The following is a description of a gene set: from publication Mili S, Moissoglu K, Macara IG (PMID 18451862) studied in species Mus musculus Mouse Gene Set: MILI_PSEUDOPODIA_HAPTOTAXIS_DN RNA localization is important for the establishment and maintenance of polarity in multiple cell types. Localized RNAs are usually transported along microtubules or actin filaments and become anchored at their destination to some underlying subcellular structure. Retention commonly involves actin or actin-associated proteins, although cytokeratin filaments and dynein anchor certain RNAs. RNA localization is important for diverse processes ranging from cell fate determination to synaptic plasticity; however, so far there have been few comprehensive studies of localized RNAs in mammalian cells. Here we have addressed this issue, focusing on migrating fibroblasts that polarize to form a leading edge and a tail in a process that involves asymmetric distribution of RNAs. We used a fractionation scheme combined with microarrays to identify, on a genome-wide scale, RNAs that localize in protruding pseudopodia of mouse fibroblasts in response to migratory stimuli. We find that a diverse group of RNAs accumulates in such pseudopodial protrusions. Through their 3' untranslated regions these transcripts are anchored in granules concentrated at the plus ends of detyrosinated microtubules. RNAs in the granules associate with the adenomatous polyposis coli (APC) tumour suppressor and the fragile X mental retardation protein (FMRP). APC is required for the accumulation of transcripts in protrusions. Our results suggest a new type of RNA anchoring mechanism as well as a new, unanticipated function for APC in localizing RNAs. Transcripts depleted from pseudopodia of NIH/3T3 cells (fibroblast) in response to haptotactic migratory stimulus by fibronectin, FN1., and this is the list of marker genes: Ccnt1, Clasrp (NCBI Gene Id 53609), Sgms2, Fbxo34, Snai1, Kantr, Glrx3, Tlcd1, Tor1b (NCBI Gene Id 70214), Cxcl5, Sptlc2, Oaf, Syvn1, Tspan31, Lrig3, Tex261, Nfib, Kdsr, Ubac2, Col1a2, Sec61a1, Cnot3, Arhgef7, Erlin1, Tram2, Tnrc18 (trinucleotide repeat containing 18), Tmem33, Tmem161a, Slc38a4, Cldn9, Rnasek, Pcnx3, Ube2i, Mfsd10, Arxes2, Pigk, Slc20a1, Slc35b2, Cdc20, Lif, Lman2, Gcn1, Slc16a13, Actl6a, B3gnt2, Qpctl, Tbl2, Atp6ap1, Sec11a, Amotl2, Pdcd11, Bltp2, Hyal2, Ptges, Kif22, Ctsz, Ppil2, Son, Rtn3, Neo1, Slc19a1, Dcbld1, Efnb1, Pigu, Scamp3 (secretory carrier membrane protein 3), Ces2g, Cmtm6, Pcdh19, Slc7a6, Sppl3, Sema4c, Itpr3, Itgb1, Poglut2, Thbd, Gjb3, Hacd3, Heg1, Zbtb39, Esyt1, Cds2, Gba1, Arhgap23, Pdia4, Itga5, Ece1, Col4a5, Btd, Sgpl1, Sting1, Tmed10, Fkbp10, Tgfb1, Fzd7, Creb3l2, Abcb10, Yipf3, Scarb1, Ephb2, Pla2g15, Sod3, Cd151, Erg28, Fbxl6 (NCBI Gene Id 30840), Srebf2, E2f2, Hmmr, Ptprf, Adcy6, Fam83d, Acvr1b, Chsy1 (chondroitin sulfate synthase 1), Gpr89, Sptlc1, Plk1, Zdhhc24, Taf1d, Fitm2, Tspan14, Tmed7, Timp2, Mmp2, Minpp1 (NCBI Gene Id 17330), Pear1, Rtn4, Clptm1l, Aqp1, Cd81, Kansl3, Srprb, Lhfpl6, Cnpy3, Phrf1, Abcc5, Smpd1, Selenos, Efna1, Cd276, Ext2, Enc1, Aplp2, Numa1, Cd34, Mfsd11, Pxylp1, Nagpa, Slc36a1, Ncam1, Erbb2, Gas2l3, Slc44a2, Ergic1, Hjurp, Gjc1, Axl, Spcs2, Nid1, Entpd6, Sgpp1, Tmem201, Laptm4b, Cyb561d2, Tgfbr3, Tnfrsf21, Scamp2, Taf5l, Tmem109, Angptl2, Itga3, Steap3, Cd109, Men1, Mfsd5, Phb2, Zdhhc9, Thbs1, Ankrd11, Tmed9, Rnf10, Gga2 (golgi associated, gamma adaptin ear containing, ARF binding protein 2), Slc38a2, 1600012H06Rik, Raet1d, Sppl2a, Sdc1, Pomgnt2, Ubiad1, Mia3, Soat1, Rps10, Nptxr, H2-Q5, B3galt6, B4galt5, Plod3 (NCBI Gene Id 26433), Mfsd1, Nlgn2, Reep3, Slc38a1, Tmem158, Prkcsh, Ltbp2, Sparc, Sbno2, Marveld1, Txndc11, Chpf, Ttc19, Fkbp2, Atp6v0a1, Vcp, Hacd2, Slc9a5, Nfkb2, Mir1949, Flnb, Tm9sf2, Htt, Slc23a2, Unkl, Il17rd, Trim35, Ccdc134, Hsd17b7, Slc38a10, H2-D1, Atg9a, Tspan4, Plxna1 (NCBI Gene Id 70046), Tspan9, Sgms1, Lclat1, Ermp1, Sec61a2 (SEC61 translocon subunit alpha 2), Kifc5b, Iqgap1, Ckap4, Rnf26, Il4ra, Tmem185a, Ndst2, Serpinh1, Miga2, Cd99l2, Ano10, H2-DMb1, Trim45, Bsg, Ppfibp1, Nptn, Plec, Mgat1, Ahsa1, Med15, Dpf2, Slc20a2, Dusp1, Ly6e, Atp10d, Tmem115, Scd2, Abcc1, Layn, Prss23, Tinagl1, Srebf1, Usp19, Igf1r, Emc7, Ap2a2, Hs2st1, Tmem101, Abhd1, Rpn1, Col4a1, Znrf3, Slc35e2, Qsox1, M6pr, Icmt, Slc49a4, Plxnb2, Esyt2, Fkbp11, Zfp263, Slc7a5, Atf6b, Tmem41b, Slc19a2, Dpagt1, Pttg1ip, Zcchc14, Tm9sf4, Glmp, Clcn6, Psmd7, Nhlrc2, Dram1, Hoxd4, Lrp12, Lipa, Polg, Itm2c, Trio, Adam17, Tm9sf3, Ogt, Atp10a, Cklf, Ptpn23, Tmem245 (NCBI Gene Id 319762), Trib1, Pank4, Rap1gap2, Hsd17b12, Degs1, Faf2, Cst3, Tln1, Mpdu1, Unc50, Sf3b3, Mfsd14b, Cdip1, Slc5a6 (solute carrier family 5 (sodium-dependent vitamin transporter), member 6), B4galt1, Fzd2, Fzr1, Tmem63a, Snora65, Plagl2, Slco2a1, H2-K1, Wiz, Sys1, St3gal2, Il17ra, Cables2, Gaa, Hgsnat, Zdhhc5, Ctns, Hoxb3, Tbc1d25, Fgfr1, Pald1 (phosphatase domain containing, paladin 1), Thbs3, Jagn1, Stt3a, Alg9, Bicd2, Apmap, Tmbim6, Hbegf, Cyp4f16, Slc66a1, Cldn12, Tm2d3, Emc1, Cant1, Adora2b, Ccl2, Smpd3, Tapt1, Atp1a1, Adgrl2, Ogfod3, Igfbp6, Exosc10, Poldip3, Ilvbl, Nedd4l, Endod1, Lmf2, Derl2, Ddr1, Igsf8, Tmem63b, Wdr62, Sigmar1, Tmem19, Bmp1, Ttll4, Nectin2, Slc4a7, Cers2, Ctif, Atp13a1, Pcdh1, Slc35f6, Atg16l1, Pigo, Proser1, Tmem248, Rer1, Slc16a1, Gja1, Rps9, Zc3h4, Adrb2, Brip1os, Kdelr2, Pdia5, Slc46a1, Rps24, Surf4, Fam171a1, Dtna, Zfp740, S1pr3, Mgat2, Crtap, Ltbp3, Ssr3 (NCBI Gene Id 99923), Slc39a6, Tpbg, Ctsd, Cdan1, Cd9, Helz2, Snx21, Slc2a10, Pdia6, Elovl5, Tm9sf1, Tmem259, Flna, Mfhas1, Mlec, Adgra2, Zfp266, Gpc1, Lmtk2, D17H6S56E-5 (DNA segment, Chr 17, human D6S56E 5), Gprc5b, Scfd1, Mfsd14a, Eppk1, Tmem184b, Sppl2b, Tmem97, Mydgf, Rgmb, Akap1, Ptdss2, Hspg2, Msmo1, Ankle2, Slc52a2, Nrm, Tmx2, Gprc5a, Pdgfrb, Ptgs1, Elovl1, Ube4a, Ptprk, Tmbim4, Ifnar2, Msln, Ltbp1, Trim11, Ssh1, Lrp1, Slc2a1, Tor1a, Gns, Slc39a14, Zfp36, Zmynd8, Tor2a, Sft2d1, Slc27a4, Gm33887, Baiap2, Csf1, Ccdc107, Tnfrsf23, Vars1, Prdx4, Pim3, Uxs1, Srd5a3, Pkmyt1, P4ha1, Cd47, Cpd (NCBI Gene Id 12874), C2cd2l, Alg12 (NCBI Gene Id 223774), Zzef1, Tpcn2, Mafg, Ptch1, Polr3a, Nisch, Tyw1, Clcf1, Ppp1r15b, Flnc, Atp6v0a2, Glg1, Piezo1, Calu, Suco, Ebp, Dpy19l3, Ndst1, G6pc3, Slc22a23, Slc10a3, Pofut2, Txndc15, Adgra3, Hspa5, Slc9a1, Ano6, Polrmt, Slc30a5, Ddost, S1pr2, Eif2ak3, Tssc4, Stc2, Cdipt, Mmgt2, Socs1 (suppressor of cytokine signaling 1), Slc50a1, Tnfsf9, Il6st, Loxl3, Glb1, Pdia3, Sqle, Slc30a1, Ganab, Clstn1, Ipo4, Arid1a, Spata2, Sbf1, Slc30a6 (NCBI Gene Id 78426), Il34, Plpp1, Pigs, Tspan11, Tm2d2, Manf, Incenp, Ncln, Mfge8, Lrp10, Slc39a7, Ston1, Nol11, Tmem86a (NCBI Gene Id 67893), Pcolce, Creg1, Psen1, Gtf3c1, Creb3, Tnfrsf1b, Gramd4, Got2, Hmgcr, Slc39a10 (solute carrier family 39 (zinc transporter), member 10), 6030458C11Rik, Orai1, Mboat7, Zfp142, Nagk, Jkamp, Atp11a, Xxylt1, Cmtr1, Tgoln1, Slc12a4, Pan3, Fgfrl1, Mogs (mannosyl-oligosaccharide glucosidase), Ccl7, Gusb, Tmppe, Neat1, P4ha2, Tyms (thymidylate synthase), Tmem43, Kcnn4, Slc30a7 (solute carrier family 30 (zinc transporter), member 7), Rpl30, Slc35a2, Clcn7, Chst14, Large1, Tnfrsf12a, Rack1, Armc9, Atp2a2, Slc39a13, Slc35b4, Ptprs, Ank, Slc29a1, Slc45a4, Rps17, Ankrd39, Spns1, Myadm, Tut1, Ldlr, Por, Mir6963, St6galnac4, Slc41a1, Leng8, Shisa5, Dag1, Ttc7, Syngr2, Rnf121, Rnps1, Xpot, Tspan6, Kmt2b, Tex2, Dgcr2, Tmed1, Dcbld2, Dolk, Retsat, Cers5, Ormdl2, Chuk, Ggta1 (glycoprotein galactosyltransferase alpha 1, 3), Puf60, Setd1a, Itprip, Taf1c, Gla, Sc5d, Gdnf, Ctr9, Mpzl1, Ppm1l, Pcdhgb1, 2510039O18Rik, Ephb4, Dhrs13, Colgalt1, AI467606, Zfyve27, Grn, Mrc2, Dad1, Dnajc1, Lman1, Col4a2, Alg3, Fam3a, Sfswap, Sri, Ctsl, Slc9a6, Lamb1, Pigx, Nsmce3, Btg2, Ttc13, Slc43a3, Abhd12, Vasn, Rai1, Bcap31 (B cell receptor associated protein 31), Dnajc22, Atp6v0b, Vcl, Pimreg, Pomt2, Slc11a2, Pxdn, Dhrs7b (dehydrogenase/reductase 7B), Serinc1, Tmco3